Given this list of marker genes Lin37, Rbbp4, Rbl2, Lin54, Ccne2, Ccne1, Tfdp1, Ccna1, Lin52, here is a description of the gene set: This event has been computationally inferred from an event that has been demonstrated in another species.<p>The inference is based on the homology mapping from PANTHER. Briefly, reactions for which all involved PhysicalEntities (in input, output and catalyst) have a mapped orthologue/paralogue (for complexes at least 75% of components must have a mapping) are inferred to the other species. part of: Mitotic G1 phase and G1/S transition electronically inferred by orthology from the curated human pathway Reactome Pathway: G0 and Early G1 species: Mus musculus